The following is a description of a gene set: Reactome Pathway: Leishmania parasite growth and survival Leishmania parasites infecting macrophages are considered a good model to study successful evolutionary mechanisms of evasion of the macrophage mediated immune response. To evade killing by the host, Leishmania parasites manipulate the host's cellular signaling mechanisms, to prevent the production of microbicidal molecules and stimulating the activation of protective signaling pathways or to interfere with effective antigen presentation. In most natural infections or after the resolution of the disease, a few Leishmania parasites remain in the host, perhaps as a product of a balance between forces favouring parasite persistence and those favouring destruction.<br><br> species: Homo sapiens part of: Leishmania infection, and this is the list of marker genes: IGKV2-30, ADCY7, CD247 (NCBI Gene Id 919), IGLV3-12, PLK2, IGKV1D-39, GNG7, YES1, PRKAR2B, IGKV2D-28, GNB2, CYSLTR1, PRKX, IGLV3-27, IGKV3-11, IGLC2, GNB3, IGHV3-33, DPEP2, IGHV3-30, IGHV4-34, GNAI3, IGLV2-18, FCGR2A, IGLV, PLCG1, GNG4, IGLV4-60 (immunoglobulin lambda variable 4-60), IGLV3-16, IGLV1-51, IGLV5-37, IGLV3-19, GNG3, GNB1, SYK, PRKAR1B, ITPR3, IGKV1D-16, IGHV1-2, IGHV7-81, GNGT1, IL6, CYSLTR2, IGLV7-43, HCK, ADCY6, FCGR3A, IGHV3-9, IGLV2-11, IGKV3D-20, GNG13, IGLV1-40, IGHV1-69, IGHV3-11, IGKV4-1, IGLV1-47, GNG11, IGKV1-33, IGLV2-8, ITPR1, IGHV3-48, RHBDF2, IGHV1-46, IGKV1D-12, LYN, GNAZ, FYN, IGHG1, IGLV3-1, GNAS, FCGR1A (NCBI Gene Id 50698), IGKV1-5, IGLV1-36, IGKV1D-33, DPEP1, GNG10, IGKV2D-40 (NCBI Gene Id 28878), IGKV1-39, GNG5, IGKV5-2, CALM1, ADCY8, PRKACG, IGLV2-33, IGHV, GGT1, IGLV8-61, GNG2, IGLV3-22, IGHG3, IGKV1-17, IGHG4, ADCY5, IGLV1-44, IGLV2-23, FGR, GNB4, IGKV3-15, PRKAR1A, CD3G, IGLV6-57, ADCY3, ADAM17, GNB5 (G protein subunit beta 5), IGLV2-14, IGKC, PLCG2, IGHV2-5, MAPK14 (NCBI Gene Id 1432), PRKAR2A, IGHV4-39, FURIN, ADCY2, ADCY9 (adenylate cyclase 9), IGLC1, IGLV7-46, IGKV3-20, IGKV2-28, IGKV1-16, GNG8, GNG12, IGLV3-25, IGKV2-29, IGHG2, IL10, IGLV4-3, IGHV4-59, ADORA2B, IGHV3-53, IGLC6, SRC, CREB1, ADCY4, IGLV10-54, AHCYL1, ITPR2, IGLC7, GGT5 (NCBI Gene Id 2687), GNAT3, IGLC3, IGLV3-21, PRKACA, IGHV3-7, PRKACB, IGLV11-55, IGLV4-69, ADCY1, IGHV3-23, IGHV3-13, GNGT2, GNAI1, IGHV2-70, GNAI2, IGKV1-12, IGLV5-45, LPG1G2, IGKV2D-30, CD163, MYH9